Given this list of marker genes USP15, VAMP4, LHX4, SORBS2, DLL1, RAPGEF6 (NCBI Gene Id 51735), TMEM115, KCNIP4, CAPN3 (NCBI Gene Id 825), PIGA, EIF3A (NCBI Gene Id 8661), TBC1D25, BCL11A, SGIP1, NMT1, P3H1, EDEM1, TCEA1, LUC7L3, SEC31B, EIF2S2, LGALS3, RNF145, PSD3, LENEP, SPATA2, RBM46, TRIM3, CHSY1, CNTN4, STRN3, GADD45A, YTHDF3, RNF24, SEMA4F, CTCF, SUGP1, SRGAP2, SMG1, GPR180, GRIA3, DNAJC11, PRKCA, CPEB4, DVL3, CDK5R1, ACVR2A, KCNMA1, NOL4 (NCBI Gene Id 8715), ISL1, DBNDD2, OLIG3, LRRTM4, TLE4, PLAGL2, ACACA, GLIS2 (GLIS family zinc finger 2), RC3H1, KDM5C, NPEPPS, PLP1, MIER3, HOXD3, RIMS4, SPTY2D1, DENND6A, here is a description of the gene set: species: Homo sapiens Genes having at least one occurence of the motif CAAGGAT in their 3' untranslated region. The motif represents putative target (that is, seed match) of human mature miRNA hsa-miR-362 (v7.1 miRBase). Human Gene Set: CAAGGAT_MIR362